The following is a description of a gene set: species: Homo sapiens Human Gene Set: GSE43955_TH0_VS_TGFB_IL6_TH17_ACT_CD4_TCELL_10H_DN from publication Yosef N, Shalek AK, Gaublomme JT, Jin H, Lee Y, Awasthi A, Wu C, Karwacz K, Xiao S, Jorgolli M, Gennert D, Satija R, Shakya A, Lu DY, Trombetta JJ, Pillai MR, Ratcliffe PJ, Coleman ML, Bix M, Tantin D, Park H, Kuchroo VK, Regev A (PMID 23467089) Despite their enormous importance, the molecular circuits that control the differentiation of Th17 cells remain largely unknown. Recent studies have reconstructed regulatory networks in mammalian cells, but have focused on short-term responses and relied on perturbation approaches that cannot be applied to primary T cells. Here, we develop a systematic strategy – combining transcriptional profiling at high temporal resolution, novel computational algorithms, and innovative nanowire-based tools for performing gene perturbations in primary T cells – to derive and experimentally validate a temporal model of the dynamic regulatory network that controls Th17 differentiation. The network is arranged into two self-reinforcing and mutually antagonistic modules that either suppress or promote Th17 differentiation. The two modules contain 12 novel regulators with no previous implication in Th17 differentiation, which may be essential to maintain the appropriate balance of Th17 and other CD4+ T cell subsets. Overall, our study identifies and validates 39 regulatory factors that are embedded within a comprehensive temporal network and identifies novel drug targets and organizational principles for the differentiation of Th17 cells. Genes down-regulated in CD4 T helper cells (10h): Th0 versus TGFB1 and IL6., and this is the list of marker genes: KARS1, B4GALT3, SIM2, LY75, GAS8, FAM162A, LPP-AS2, SLC41A1, FLNA, ENTPD5, NCOA5, RBKS, LINC00612, CDKN2D, DIAPH1, ANKRD49, CRYBG1, HPF1, NLRX1, CX3CR1, CYP4A11, CCNA2, MPO, PIGA, IYD, KRT1, CXCL9, PTN, BRD4, ADM, DUSP16, CALU, DDHD2, MAP2K6, WFS1 (wolframin ER transmembrane glycoprotein), FKBP10, MAP3K1, NFATC1, AARS1, HTR2C, DLG3, XRCC5 (NCBI Gene Id 7520), GADD45G, SGCD, MPRIP, NBL1, NKX2-3, SOX18, AMBN, ERGIC3, HBB, HLX, PPP4R2, PEG3, NR2F1, FIS1, CYP2S1, DHX30 (NCBI Gene Id 22907), RAC2, PRNP, WNT10A, TET1, SELP, PROCR, HOXA11, HAL, PIPOX (NCBI Gene Id 51268), ADRA2C, PTPN20, HDHD2, MOS, MMP24, LARP1, MED12L (mediator complex subunit 12L), FOXB1, LPAR1, KCNA7, SLC22A23 (solute carrier family 22 member 23), IL4R, RALY, NSMCE1, CACNG1, CHRND, EXOSC7, CA2, MYF5, KLRD1, EMB, TAT, PRRX1, EEF1B2, IL1RN, IL6, COQ3, NDRG1, SNORA7A, TRIM46, ZMIZ2, EIF3B (NCBI Gene Id 8662), SLC35C2, NOBOX, ICOS, RYK, PRG3, ASPSCR1, CCL4 (NCBI Gene Id 6351), H1-8, STRA8, GUF1, IRF3, CGA, CEBPD, FANCM, CISH, SPINT1, HLA-E, SH3PXD2A, FZD6, FEZF2, TIMM44, PRKCG, TARS2, GBP2, FRZB, TENM1, BCAN, GPR162, GBP4, PHF12, DKK1, HOXD1, FZD7, MBD4, IL11, PRM3, NR2F2, NPR1, GABPB1, MACROD2, CDH5, EEF2, ANGPT1, UBR5, APLP1, TEAD3, RASA4, SLC25A3, NKX2-8, TMEM38B, NKIRAS2, CSF3R, DOCK7, ZSCAN21, TLL1, MT1E, MAFB, CCN5, STAB1, BMPR1B, IL13RA1, INSM1, SLC3A1, IL18BP, UBR7, ANKRD10, FNDC7, DPYSL4, GABRA2, SAA1 (serum amyloid A1), NCOR1, RMDN3, PSMD1, CRYGB, MRPS33, STK39, CXCR2, CAMK2B, RAD23A, ITIH2, MYD88, IL17RA, BAZ1B, POU1F1, CHFR, ARG1, IDNK, PROM1, GPN3, LEFTY1 (NCBI Gene Id 10637), CHAF1B, NMU, SSC4D (NCBI Gene Id 136853), RIPK1, HOXD12, SKAP2 (NCBI Gene Id 8935), EXTL3, S100A5, APP, TRO, COMMD1